The following is a description of a gene set: from publication Nakaya HI, Wrammert J, Lee EK, Racioppi L, Marie-Kunze S, Haining WN, Means AR, Kasturi SP, Khan N, Li GM, McCausland M, Kanchan V, Kokko KE, Li S, Elbein R, Mehta AK, Aderem A, Subbarao K, Ahmed R, Pulendran B (PMID 21743478) Genes up-regulated in comparison of peripheral blood mononuclear cells (PBMC) from LAIV influenza vaccinee at day 3 post-vaccination versus those at day 7 post-vaccination. studied in species Homo sapiens Human Gene Set: GSE29615_DAY3_VS_DAY7_LAIV_FLU_VACCINE_PBMC_UP Systems vaccinology has emerged as an interdisciplinary field that combines systems wide measurements and network and predictive modeling applied to vaccinology. Here we used the systems vaccinology approach to study the molecular mechanisms underlying the innate responses to the trivalent inactivated influenza (TIV) and live attenuated influenza (LAIV) vaccination in humans, and to identify early gene signatures that predict the magnitude of the antibody responses to influenza vaccination., and this is the list of marker genes: ALLC, ADAM30, NUDT3, MMP25, CBL (NCBI Gene Id 867), AVP, NAV3, MYL11 (NCBI Gene Id 29972), FAM228A, LINC00924, RAB2B, SPARC, CTNNA2, SV2B, CSF3, SPDYA, C1QL1, AK7, ADAMTS7, IGKV1-5, SV2C, PUM1, AURKC, RIPPLY3, IFT74, FGL2, WDR49, ZC3H4, SLC39A13, GJB1, TMEM125, ZPBP2, AFG3L2, HOGA1, HSD17B4, SUN5, ELOA2, RNF145, ZNF853, LINC01600, NPAS3, DECR1, RNF170, ELANE, DNAJC28, DELEC1, PPBP, SLC18A2, PPP2R5B, ZNF706, DPP10-AS1, CNDP2, LINC02875, GDF11, NORAD, SERPINA3, FGF10, LARP1, SLC5A4, EVPL, ANKRD45, TNFRSF17, RHOF, USP11, ISCA2, MUL1, UBR1, NEFM, ITIH6, RAPGEF4-AS1, TMEM106C, SELENBP1, MPP2, SOX21 (SRY-box transcription factor 21), ATG101, SYNRG, CIMAP2, DEPDC1, L3MBTL2, BMERB1, LINC01088, MARCHF2, SMCO3, TRPV3, PGLYRP2, CXCR3, UBALD1, CACNG8, GCG, SPR, LINC01304, IFT172, IKZF1, FAM117A, SOX5, SYT9-AS1, LHFPL5, ZBTB47, BEX3, FBXW5, ACSM5, DNAH17-AS1, MADCAM1, AHSP (alpha hemoglobin stabilizing protein), DNAAF11, FSCN3, ENSG00000124835, ID4, TAT, SLC4A5, UBN2, COL22A1, PLXNA2, TMEM203, ZNF512, MEAK7, AR, AP3D1, CDT1, LINC00865, ZC3H10, PCYOX1, LIFR, LRBA (LPS responsive beige-like anchor protein), CLCN3, LCN2, GPR50, TUBB, KRT35, CLRN3 (NCBI Gene Id 119467), SPINK5, CASP6, FOXO4, MTMR9LP, PIP4K2B, ERC2-IT1, DCST2, ARX, KIRREL1, VENTX, CERCAM, FECH, TERT, SLC7A1, CIRBP-AS1, SKA1, METTL25, ZKSCAN1 (zinc finger with KRAB and SCAN domains 1), LGI3, TASOR, LARP4, PSTPIP2, TEX26-AS1, AQP11, PDE11A, KDM7A-DT, E2F4, SNHG28, TTC16, FAM167B, RAVER2, IPCEF1, APBA1, MZB1, ATP8B5P, PLD5, PF4, WDR37, RHD, ANGPTL3, SNTN, BTBD6, ECH1, CHMP3, CA3, ARHGAP19, DAB2, C2CD5, DQX1, SCN10A, FERD3L, NFAT5, LINC00511, IRF6, TUBB1, MMD, TNPO2, TCEAL8, ENSG00000293136